Given this list of marker genes Ywhaz, Tmed7, Lrp4, Ttbk2, Ctsb, Pdha2, Vapb, Rnf41, Man2a1 (mannosidase 2, alpha 1), Ammecr1, Gdi1, Supt5, Lingo1 (leucine rich repeat and Ig domain containing 1), Gm2a, Sertad3, 6430550D23Rik, Rnf17, Ttc39d, Col4a4, Naa20, Igsf9b, Foxn3, Sec22c, Fam219b, Fgf9, Ogt, Nkx2-1, Mobp, Zfp710, Fbxw7, Ncbp3, Lamc1, Stat2, Slc7a15, Vwc2, Naa50, Stk32b, Srgap3, Zc3h7a, Slc35d1, Maml2, Dnajc5, Gjb2 (NCBI Gene Id 14619, gap junction protein, beta 2), Trmt6, Ranbp10, Fam219a, Tmem144, Rlig1 (NCBI Gene Id 75940), Tat, Trim67, Slc15a1, Mtcl2, Minar2, Parvb, Capn1, Pip4p1, Dlgap4, Akap8, Osm, Gca, Mlph, Entpd7, Igdcc4, Dcdc2a, Gdpd4, Pea15a, Bsn, Nrn1, Mcu, Clic6, Gje1, Vezt, Actn1, Snhg11, Vezf1, Gpr45, Bcl11b, Trim39, Cstpp1, R3hdm1, Ark2c, Desi1, Sox13, Lbh, Agap1, Mnat1, Inpp5a, Hexim1, Rnf150, Amer2, Plxna4, Lrrc8d, Gmfb, Gal3st3, Snx12, Mybpc1, Pnma8b, Tmx2, Trim66 (NCBI Gene Id 330627), Arf3, Rab6b, Gskip, Ier3, Rufy2, Icosl, Fam131b, Exph5, Ikzf3, Mospd3, Sarm1 (sterile alpha and HEAT/Armadillo motif containing 1), C5ar1, Cplx1, Skint7, Il2ra, Kcnj6, Cd320, Cdc42ep4, Atp7a, 1110004F10Rik, Usp11, Zfp512, Hacd1, Rnd3, Trim35, Evi2b, Prg4, Kif3a, Gm4984, Man1a, Usp46, Arid1a, Plscr2, Tmem101, Mylk4, Baz2a, Abl1, Cgn, Sult5a1, Nhsl2, Stard5, Itsn1, Plb1, Abcg4, Adamts15, Supt16, Prop1, Cyp2b13, Zic4, Gpc6, Fam76a, Pitpnb, Otud7b, Glg1, 4930558K02Rik, Cpa4, Sbk3, Ppp1r1c, Siglecl2, Srl, Sypl2, Pomk (protein-O-mannose kinase), Kirrel1, here is a description of the gene set: species: Mus musculus from publication Chen Y, Wang X (PMID 31504780) Genes predicted to be targets of miRBase v22 microRNA mmu_miR_6942_5p in miRDB v6.0 with MirTarget v4 prediction scores > 80 (high confidence targets). Mouse Gene Set: MIR_6942_5P